The following is a description of a gene set: A nuclear telomere cap complex that is formed by the association of telomeric ssDNA- and dsDNA-binding proteins with telomeric DNA, and is involved in telomere protection and recruitment of telomerase. The complex is known to contain TERF1, TERF2, POT1, RAP1, TINF2 and ACD in mammalian cells, and Pot1, Tpz1, Rap1, Rif1, Rif2 and Taz1 in Saccharomyces. Taz1 and Rap1 (or their mammalian equivalents) form a dsDNA-binding subcomplex, Pot1 and Tpz1 form an ssDNA-binding subcomplex, and the two subcomplexes are bridged by Poz1, which acts as an effector molecule along with Ccq1. Human Gene Set: GOCC_SHELTERIN_COMPLEX species: Homo sapiens, and this is the list of marker genes: TERF1, TERF2IP, TERF2, TERB1, ACD, TINF2, POT1